Given this list of marker genes ACTB, CCT4, TCP1 (NCBI Gene Id 6950), CCT3, CCT2, CCT5, CCT7, CCT8, CCT6A, CCT6B, here is a description of the gene set: Nucleotide-independent transfer of beta-actin from prefoldin to CCT occurs when prefoldin binds to CCT. Following ATP- dependent folding within CCT, beta-actin is released as a soluble, monomeric protein. Reactome Pathway: Folding of actin by CCT/TriC part of: Cooperation of Prefoldin and TriC/CCT  in actin and tubulin folding species: Homo sapiens